Given this list of marker genes MYL9, RHOA, ROCK2, MYL5, ROCK1, MYL11, MYL10 (myosin light chain 10), MYL7, MYL12A, MYL2, MYL12B, here is a description of the gene set: species: Homo sapiens Pathway Definition from KEGG: IpaA -> RHOA -> ROCK1/2 -> MLC Shigella IpaA to ITGA/B-RhoGEF-RhoA signaling pathway. Pathway ID: N01074. Pathway type: Pathogen. Pathway class: nt06135 Cytoskeletal regulation (viruses and bacteria). Human Gene Set: KEGG_MEDICUS_PATHOGEN_SHIGELLA_IPAA_TO_ITGA_B_RHOGEF_RHOA_SIGNALING_PATHWAY